Given this list of marker genes RPS23, LNPEP, RABL3, SH3BP2, HTR1F, CETN3, PDCD10, ZFP64, ZNF749, USP38, ABCC10, RELL1, PTPRT (protein tyrosine phosphatase receptor type T), ZMYM3, SSBP2, GOLGA6L1, KNCN, VPS4A, SOX6, ENPEP, TRUB1, KIF2A, MAPK9, IL2RA, GPR180, LRFN5, CCSER2, PIGW, GCNT1, FBXO32, HDAC2, EFHC2, FAM168B, DCBLD2, CD24, GTF2A1, ARID3B, GABBR1, ITGAD, CCDC85A, SELENOV, PLCB1, CSE1L, RIC8A, KBTBD8, TOB1, ZNF655, GALK2, DNAJA2, SLC22A2, TMEM65, PCGF5, FAM120C, FBLN1, ZNF333, ARL8B, SCYL2, ANGEL2, LCORL, CDK5R2, TSPAN32, RAB14, TMEM26, STRN3 (NCBI Gene Id 29971), CNOT9, DISC1, NEXN, UBXN2B, TRPC5, LAMC2, FAR1, RNF38, PHF14, GSK3B (glycogen synthase kinase 3 beta), PDS5B, PER2, GRIA4, COL1A2, PRICKLE2, PLCH1, KCNG3, STON2, SNX13, WDR83, ATF7, MTMR4, HNRNPR, ST6GALNAC3, DHFR, GOLGA6L6, ZDHHC15, EIF1AX, PRR27, RANBP9, PCNX4, FBXW8, PBX2, TET2, NONO, SH3TC2, SLC16A1, MTCL1, NME9 (NCBI Gene Id 347736), DEFB132, FBXO33, ENAH, WDFY3, ACOX1, CNTN4, PHC3, USP47, MYORG, N4BP2L2, STAU2, GARNL3, UBR2, INO80D, RNF170, ACVR2B, EIF4E, SLC9B2, REV1, IHH, OGFRL1, ESRRG, PLEKHG2, PCID2, ZNF716, OPA3, ARID1B, SH3PXD2A, C11orf71, RIPOR2 (NCBI Gene Id 9750), NEDD9, IFIT1, TMOD2, CLEC2A, GAREM1 (NCBI Gene Id 64762), MMP8, L3MBTL4, PRPH2, TSLP, C2CD5, KAT6A, RASAL2, UBXN8, CACNB4, RASA1, LRRC58, here is a description of the gene set: Genes predicted to be targets of miRBase v22 microRNA hsa-miR-4426 in miRDB v6.0 with MirTarget v4 prediction scores > 80 (high confidence targets). studied in species Homo sapiens Human Gene Set: MIR4426 from publication Chen Y, Wang X (PMID 31504780)